Given this list of marker genes BMPR2, HAS2, TACR1, PFN1, EPB41L4B, JUN, HBEGF, ITGA2, EPB41L5, DOCK1, CLASP1, PRKCE, MMP9, MTOR, FGF7, ARHGAP5, ADAM9, FGF10, RREB1 (NCBI Gene Id 6239), TAC1, SOX9, PTK2, ITGA3, ENPP2, GLIPR2, CTSH, MAP4K4, CAPN7, MAPRE2 (NCBI Gene Id 51683), PLCG2, PPM1F (protein phosphatase, Mg2+/Mn2+ dependent 1F), MIR222, MIR221, TGFB2, PLCG1, IFNG, RAB25, TGFBR2, VIL1, IQSEC1, SRC, DOCK5, ARF6, INSL3, RTN4, HDAC6, IRS2, CLASP2, RAB11A, HIF1A, here is a description of the gene set: Any process that activates or increases the frequency, rate or extent of epithelial cell migration. studied in species Homo sapiens Human Gene Set: GOBP_POSITIVE_REGULATION_OF_EPITHELIAL_CELL_MIGRATION